Given this list of marker genes CALM2, INSR, NDUFAF6, USP8, KCNE3, KCNE1, DEF6, TERT, CYP11B2, CLDN10, SCNN1A, GATM, SLC26A3, CALM3, KCNJ2, SERPINA6, SCN5A, SCNN1B (sodium channel epithelial 1 subunit beta), AIP (aryl hydrocarbon receptor interacting protein), TP53, KCNE2, BMPR1A, KCNQ1, PKD2, CALM1, SCN4A, TRDN, CDKN2A, SLC12A1, NR3C1, CYP17A1, CYP11B1, CTNS, HSD11B2, CACNA1D, AKAP9 (A-kinase anchoring protein 9), CAV3, SLC12A3, CLCNKB, CTNNB1, ATP1A1, CLCN2, CDH23, MAGED2, ASL, UNC45A, SLC34A1, PRKAR1A (NCBI Gene Id 5573), SCN10A, RRAGD, CACNA1S, GEMIN4, SLC2A2, NOS1AP, NUP214, CLCNKA, GABRA3, KCNJ1, SCN4B, CACNA1C, OCRL, BSND, KCNH2, TBX5, CASR, SMAD4, KCNJ18, SLC4A4, COL3A1, ATP6V0A4, SNTA1, EHHADH, FXYD2, SLC4A1, KCNJ5, ANK2 (NCBI Gene Id 4028), ZNRF3, KCNJ10, SCNN1G (NCBI Gene Id 6340), here is a description of the gene set: Human Gene Set: HP_HYPOKALEMIA An abnormally decreased potassium concentration in the blood. Hypokalemia species: Homo sapiens